Given this list of marker genes Trub2, Trub1, Rpusd4, Pus3, Pusl1, Pus1, Pus7, Pus10, here is a description of the gene set: species: Mus musculus Mouse Gene Set: GOMF_TRNA_PSEUDOURIDINE_SYNTHASE_ACTIVITY Catalysis of the reaction: tRNA uridine = tRNA pseudouridine. Conversion of uridine in a tRNA molecule to pseudouridine by rotation of the C1'-N-1 glycosidic bond of uridine in RNA to a C1'-C5.